Given this list of marker genes CXCL12, MXD4, TAB2, APOE, PGR, PSENEN, PSEN1, APH1A, NRG1, SRC, STMN1, ADAP1, HBEGF, APH1B, NRG4, ESR1, NRG2, PSEN2, STAT5A, CSN2, EREG, ADAM17, BTC, SPARC, YAP1, NRG3, NCSTN, S100B, WWOX (WW domain containing oxidoreductase), NCOR1, GFAP, ERBB4, here is a description of the gene set: Reactome Pathway: Nuclear signaling by ERBB4 Besides signaling as a transmembrane receptor, ligand activated homodimers of ERBB4 JM-A isoforms (ERBB4 JM-A CYT1 and ERBB4 JM-A CYT2) undergo proteolytic cleavage by ADAM17 (TACE) in the juxtamembrane region, resulting in shedding of the extracellular domain and formation of an 80 kDa membrane bound ERBB4 fragment known as ERBB4 m80. ERBB4 m80 undergoes further proteolytic cleavage, mediated by the gamma-secretase complex, which releases the soluble 80 kDa ERBB4 intracellular domain, known as ERBB4 s80 or E4ICD, into the cytosol. ERBB4 s80 is able to translocate to the nucleus, promote nuclear translocation of various transcription factors, and act as a transcription co-factor. In neuronal precursors, ERBB4 s80 binds the complex of TAB and NCOR1, helps to move the complex into the nucleus, and is a co-factor of TAB:NCOR1-mediated inhibition of expression of astrocyte differentiation genes GFAP and S100B. In mammary cells, ERBB4 s80 recruits STAT5A transcription factor in the cytosol, shuttles it to the nucleus, and acts as the STAT5A co-factor in binding to and promoting transcription from the beta-casein (CSN2) promoter, and may be involved in the regulation of other lactation-related genes. ERBB4 s80 was also shown to bind activated estrogen receptor in the nucleus and act as its transcriptional co-factor in promoting transcription of some estrogen-regulated genes, such as progesterone receptor gene NR3C3 and CXCL12 i.e. SDF1. ERBB4s80 may inhibit transcription of telomerase reverse transcriptase (TERT) by increasing methylation of the TERT gene promoter through an unknown mechanism.<br><br>The C-tail of ERBB4 possesses several WW-domain binding motifs (three in CYT1 isoform and two in CYT2 isoform), which enable interaction of ERBB4 with WW-domain containing proteins. ERBB4 s80, through WW-domain binding motifs, interacts with YAP1 transcription factor, a known proto-oncogene, and may be a co-regulator of YAP1-mediated transcription. The tumor suppressor WWOX, another WW-domain containing protein, competes with YAP1 in binding to ERBB4 s80 and prevents translocation of ERBB4 s80 to the nucleus. ERBB4 s80 is also able to translocate to the mitochondrial matrix, presumably when its nuclear translocation is inhibited. Once in the mitochondrion, the BH3 domain of ERBB4, characteristic of BCL2 family members, may enable it to act as a pro-apoptotic factor. species: Homo sapiens part of: Signaling by ERBB4